Given this list of marker genes UBXN2A, GABPA, GSPT1, AMMECR1, RPAP3, HACD1, MMGT1, PPIL3, NSUN2, SCRIB, LRRC8A, TXNDC5, MANEA, CRYBG3, GPN3, ABCG2, ITFG1, ADSS2, EEF2, CUL5, TPRG1L, IBTK, SLFN13 (schlafen family member 13), KDM7A, YES1, ISYNA1, VKORC1L1, TRAPPC13, SLC16A1, CSNK1E, JCAD, NPM3, SPAG9, STRAP, PRKCI, MDC1, SMPD3 (sphingomyelin phosphodiesterase 3), RMND5A, UHMK1, RANBP6, TCERG1, UTP25, SSRP1, TRMT6 (NCBI Gene Id 51605), EML4, P4HB, DHODH, NT5C3B, TMEM184C, PCGF6 (polycomb group ring finger 6), EIF2B4, MTAP (methylthioadenosine phosphorylase), PALS2, CCDC86, CRISP3, LMAN1, HUWE1, SETD7, ZNF280C, MCOLN2, BASP1, HPGDS, MBNL3, CDV3, DDX21, SLC30A4, FAM118B, LETM1, GMDS, SLC25A51, EXO1, BCCIP, IMPDH2, SLC4A1AP, EIF4E, CDC73, CD36, TNPO1, KLF3, SNHG32, ZBTB1, POLR1G, TMED2, PANK3, BEND3, RSPRY1, AFG2B (NCBI Gene Id 80051), UGCG, CDK2, CASK, LIPT1, TNFSF9, S1PR1, UCHL5, TBC1D12, NDUFAF4, PDE7A, ULK2, STT3A, SS18, PRADC1, ZBTB25, ME2, SCAMP2 (secretory carrier membrane protein 2), LANCL2, ZHX1, MAPK6, GAN, JKAMP, MTMR1, AHR, JMJD6, UBE2K, VPS13B, SLC19A2, PNPO, WDR77, WDR75, GNAQ, GAD1, FAM185A, USP30, CNOT2 (NCBI Gene Id 51498), CASD1, PUS3, ZNF397, DENND4C, FKBP4, RYR1, KCTD14, VPS8, TSEN54, GID4 (GID complex subunit 4 homolog), KCTD6, PECR, MAPRE2, DNLZ, TMEM177, NUS1, BRAF, LRWD1, BCL7C, TRMT10C, TARDBP, ARMC6 (NCBI Gene Id 93436), KLHL6, CREG1, PURB, GPR171, SLC44A1, ORMDL1, NUDT17, METTL25, SOCS3, CTBP1, SLC35F2, SRRD, SIDT2, PIP4P2, ECHDC1, MGA, ZBTB22, ZNF330 (NCBI Gene Id 94900), RDH11, FAR1, UCHL3 (ubiquitin C-terminal hydrolase L3), MEMO1, NOP14, AASDHPPT, PGRMC1, SH2D4B, FRMD3, GLG1, R3HDM1, ATP13A3, DHX33, AMIGO2, DESI1, DTWD1, SLC30A5, PTBP2, OTUD6B, SYNCRIP, GCLC, NCOA6 (NCBI Gene Id 23054), SLAIN2, TIMM21, IARS1, ZNF131, DNAAF2, NAF1, SCCPDH, USP16, SYNRG, DPY19L1, TMEM259, FOXO4, THAP4, ZNF566, PRKAG2, here is a description of the gene set: Genes down-regulated in CD8 T cells during chronic infection with LCMV-Clone 13: effectors at day 6 versus exhausted at day 30. During acute viral infections, naïve CD8+ T cells differentiate into effector CD8+ T cells and, after viral control, into memory CD8+ T cells. Memory CD8+ T cells are highly functional, proliferate rapidly upon reinfection and persist long-term without antigen. In contrast, during chronic infections, CD8+ T cells become “exhausted” and have poor effector function, express multiple inhibitory receptors, possess low proliferative capacity, and cannot persist without antigen. To compare the development of functional memory T cells with poorly functional exhausted T cells, we generated longitudinal transcriptional profiles for each. from publication Doering TA, Crawford A, Angelosanto JM, Paley MA, Ziegler CG, Wherry EJ (PMID 23159438) Human Gene Set: GSE41867_DAY6_EFFECTOR_VS_DAY30_EXHAUSTED_CD8_TCELL_LCMV_CLONE13_DN species: Homo sapiens